The following is a description of a gene set: Human Gene Set: GSE13306_TREG_VS_TCONV_SPLEEN_UP from publication Hill JA, Hall JA, Sun CM, Cai Q, Ghyselinck N, Chambon P, Belkaid Y, Mathis D, Benoist C (PMID 19006694) CD4(+)Foxp3(+) regulatory T (Treg) cells originate primarily from thymic differentiation, but conversion of mature T lymphocytes to Foxp3 positivity can be elicited by several means, including in vitro activation in the presence of TGF-beta. Retinoic acid (RA) increases TGF-beta-induced expression of Foxp3, through unknown molecular mechanisms. We showed here that, rather than enhancing TGF-beta signaling directly in naive CD4(+) T cells, RA negatively regulated an accompanying population of CD4(+) T cells with a CD44(hi) memory and effector phenotype. These memory cells actively inhibited the TGF-beta-induced conversion of naive CD4(+) T cells through the synthesis of a set of cytokines (IL-4, IL-21, IFN-gamma) whose expression was coordinately curtailed by RA. This indirect effect was evident in vivo and required the expression of the RA receptor alpha. Thus, cytokine-producing CD44(hi) cells actively restrain TGF-beta-mediated Foxp3 expression in naive T cells, and this balance can be shifted or fine-tuned by RA. species: Homo sapiens Genes up-regulated in comparison of regulatory T cell (Treg) versus conventional T cells., and this is the list of marker genes: LAMC1, SPRYD3, TLR1, H1-8, IRX4, ZSCAN29, ERICH2, SGK1, DRD1, MAP3K21, RPRM, DNAH7, HSF2BP, NUCB2, LARP4, ZC3H12D, ASTN2, HACD4, NEFM, CD33, SLC4A7, MPI, MAGEL2 (NCBI Gene Id 54551), GPATCH11, PTGFRN, CHRNA6, SLC14A1 (solute carrier family 14 member 1 (Kidd blood group)), IL2RA, ASB15, PCBP3, CTLA4, DGKH, RSF1, C1R (complement C1r), MMP9, LRIT1, MYOM1, ADAMTSL2, SOCS2, TCEA3, OAT, SIPA1L2, TBC1D21, PROP1, PARD3, CFAP299, BCL2, ZIC4, MSX1, PER3, ICOS, IL33, PAPSS2, CYP26A1, FAM3B, HIVEP2, NBEA, FAH (fumarylacetoacetate hydrolase), DOCK1, NFIX, BCL9L, KIAA1217, REC114, SMR3A, DYNC1I1, PROCR, ZNF385B, CSRNP1, KIF3B, SDC4, MPP1, SFSWAP, ARF1, STARD9, CFAP90, RELN (NCBI Gene Id 5649), LTF, MLF1, SESN1, DELE1, SNX3, PHC3, ODC1, IKZF4, ARHGAP5, ESYT3, RNASE10, RIPK2, ENAM, DRAXIN, ABITRAM, SMPD3, DSCAML1, GPC6, ZDHHC23, PLEKHD1, ANKDD1B, RAMP1, SNX30, TBC1D7, CDHR3, ALDH1A2, TRIM17, MAP4K5, PECAM1, SLFN5, DUSP4, SERPINB9, CCND2, GPR83, LIF, TSPAN32, RNF121, TAS2R1, HBB, FKBP1A, ATP6V1E1, INPP5A, BLCAP, TRPM1, PTPRJ, C7orf50, PTPN1, THBS4, IL10RB, PRDM5, CNDP2, TSC22D1, COL1A1, SEC24A, ADAMTSL4, KIF5B, ISG20, PDCD1LG2, LCLAT1 (NCBI Gene Id 253558), TMEM100, FBXO41, MTMR3, ELOVL6, PTPN9, ZCCHC24, ASXL1, ACOX2, RTL6, TCTN3, SKOR1, IZUMO1R, ELAPOR2, DUSP9, PIM1, MYOC, ARL13A, ZNF608, IL22, BCL2L1, FAM107B, RGS2, LYRM2, CAMK2D, USP27X, GADL1, AHCYL2, FAM53B, HBEGF, REG3G, IL6ST, GBX2, PPP1R1A, YPEL2, NFATC2, SLC25A3, BACH2, VAMP3, ACO2, WWP1, TCEAL8, DOCK7, LPL, FGF12, PPM1L, ITM2C, MAP1B, SPACA1, UROS, ECM1, MAGEB5, SPINT2, CA5B, ARHGAP35, FGGY, FOXI1, CNOT6L, CCS, HIPK2, TEX38, TP53I11, LTA, NTN1, ARFGEF3, MAST4